Given this list of marker genes C2cd6, Cabyr (calcium binding tyrosine phosphorylation regulated), Tekt4, Efcab9, Slc9b1, Ift172, Efcab2 (EF-hand calcium binding domain 2), Pgam1, Tsga10, Akap4 (NCBI Gene Id 630530), Ccdc42, Spa17, Ift81, Ropn1, Catsperz, Catspere2, Fsip2, Catsperb, Cabs1, Tmem249, Enkur (NCBI Gene Id 99177), Ccr6, Catspere1, Nme8, Catsperd, Catsper1, Pfkm, Cfap119, Fscb, Spag6l, Scnn1a, Akap3, Odf2, Catsperg2, Spag6, Kif2a, Ift27, Slc9b2, Atp2b4, Catsperg1, Eno4, Slc22a14, Catsper4, Gapdhs, here is a description of the gene set: The segment of the sperm flagellum where the mitochondrial sheath ends, and the outer dense fibers (ODFs) associated with outer axonemal doublets 3 and 8 are replaced by the 2 longitudinal columns of the fibrous sheath (FS) which run the length of the principal piece and are stabilized by circumferential ribs. The principal piece makes up ~2/3 of the length of the sperm flagellum and is defined by the presence of the FS and of only 7 (rather than 9) ODFs which taper and then terminate near the distal end of the principal piece. Mouse Gene Set: GOCC_SPERM_PRINCIPAL_PIECE species: Mus musculus